Given this list of marker genes ASCC3 (activating signal cointegrator 1 complex subunit 3), NR2C1, NCAM2, SCHIP1, RAB30, CD302, DGCR5, DLX2, UFL1, SRD5A1, DMXL1, LDLRAD4, RB1CC1, RCN2 (NCBI Gene Id 5955), AHCYL2, MARCHF6 (NCBI Gene Id 10299), ATP6V1A, PLXNC1, AKAP3, RALGAPB, STRN, STXBP3, DUSP10, here is a description of the gene set: Genes up-regulated in MCF-7 cells (breast cancer) by selective estrogen receptor modulators (SERM) 4-hydroxytamoxifen, raloxifene, or ICI 182780 but not by estradiol. studied in species Homo sapiens Human Gene Set: FRASOR_RESPONSE_TO_SERM_OR_FULVESTRANT_UP Selective estrogen receptor modulators (SERMs) such as tamoxifen are effective in the treatment of many estrogen receptor-positive breast cancers and have also proven to be effective in the prevention of breast cancer in women at high risk for the disease. The comparative abilities of tamoxifen versus raloxifene in breast cancer prevention are currently being compared in the Study of Tamoxifen and Raloxifene trial. To better understand the actions of these compounds in breast cancer, we have examined their effects on the expression of approximately genes, using Affymetrix GeneChip microarrays, with quantitative PCR verification in many cases, categorizing their actions as agonist, antagonist, or partial agonist/antagonist. Analysis of gene stimulation and inhibition by the SERMs trans-hydroxytamoxifen (TOT) and raloxifene (Ral) or ICI 182,780 (ICI) and by estradiol (E2) in estrogen receptor-containing MCF-7 human breast cancer cells revealed that (a) TOT was the most E2-like of the three compounds, (b) all three compounds either partially or fully antagonized the action of E2 on most genes, with the order of antagonist activity being ICI > Ral > TOT, (c) TOT and Ral, but not ICI, displayed partial agonist/partial antagonist activity on a number of E2-regulated genes, (d) several stimulatory cell cycle-related genes were down-regulated exclusively by ICI, (e) the estrogen-like activity of Ral nearly always overlapped with that of TOT, indicating that Ral has little unique agonist activity different from that of TOT, and (f) some genes were specifically up-regulated by TOT but not Ral, ICI, or E2. Hence, gene expression profiling can discern fundamental differences among SERMs and provides insight into the distinct biologies of TOT, Ral, and ICI in breast cancer. from publication Frasor J, Stossi F, Danes JM, Komm B, Lyttle CR, Katzenellenbogen BS (PMID 14973112)